Given this list of marker genes ENDOG, APAF1, DFFA, NMNAT1, BAX, HSF1, GATA5, CIDEA, IL6, DFFB, here is a description of the gene set: studied in species Homo sapiens Any process that modulates the frequency, rate or extent of DNA catabolic process. Human Gene Set: GOBP_REGULATION_OF_DNA_CATABOLIC_PROCESS